The following is a description of a gene set: Genes requiring MLL for H3K4me3 and expression in MEF cells (embryonic fibroblast). from publication Wang P, Lin C, Smith ER, Guo H, Sanderson BW, Wu M, Gogol M, Alexander T, Seidel C, Wiedemann LM, Ge K, Krumlauf R, Shilatifard A (PMID 19703992) species: Mus musculus A common landmark of activated genes is the presence of trimethylation on lysine 4 of histone H3 (H3K4) at promoter regions. Set1/COMPASS was the founding member and is the only H3K4 methylase in Saccharomyces cerevisiae; however, in mammals, at least six H3K4 methylases, Set1A and Set1B and MLL1 to MLL4, are found in COMPASS-like complexes capable of methylating H3K4. To gain further insight into the different roles and functional targets for the H3K4 methylases, we have undertaken a genome-wide analysis of H3K4 methylation patterns in wild-type Mll1(+/+) and Mll1(-)(/)(-) mouse embryonic fibroblasts (MEFs). We found that Mll1 is required for the H3K4 trimethylation of less than 5% of promoters carrying this modification. Many of these genes, which include developmental regulators such as Hox genes, show decreased levels of RNA polymerase II recruitment and expression concomitant with the loss of H3K4 methylation. Although Mll1 is only required for the methylation of a subset of Hox genes, menin, a component of the Mll1 and Mll2 complexes, is required for the overwhelming majority of H3K4 methylation at Hox loci. However, the loss of MLL3/MLL4 and/or the Set1 complexes has little to no effect on the H3K4 methylation of Hox loci or their expression levels in these MEFs. Together these data provide insight into the redundancy and specialization of COMPASS-like complexes in mammals and provide evidence for a possible role for Mll1-mediated H3K4 methylation in the regulation of transcriptional initiation. Human Gene Set: WANG_MLL_TARGETS, and this is the list of marker genes: IGF2BP3, GALNT12, KIF21A, FOXC2, SPRR1A, SOX5, F5, TMEM140, MMP13, FAM20A, HOXB5, IL1RL1, COL14A1, RSRC1, SLIT2, CYP2F1, HOXC6, CYBA, GSTT2, EBF3, HCAR2, CXCL2, PLEK, ATP2B1, VEGFC, TREM2, RABGAP1L, IGFBP6, CISH, SFRP1, DMBX1, PTHLH, KAZALD1, DLL1, CDO1, PDE9A, GAL3ST1, SLC10A6, PTPRM, HOGA1, PPM1L, STAT5A, CD14, AR, PCBD1, C2, TBC1D8, CES2 (carboxylesterase 2), ZIC2, HOXC5, SLC7A2, ETV1, HCCS, COL2A1, B3GALT4, GRB10, PARP14, DGKA, LRIG3, C4BPA, ABCA9 (ATP binding cassette subfamily A member 9), WNK4, RIDA, CLMP, SLIT3, SLC27A3, FABP4 (fatty acid binding protein 4), STXBP6, GATA6, TOX, ANGPT1, PELI2, COL6A1, IL6, FOXS1, RAB3IL1, PKP3, RUBCNL, LDHB, DKK3 (dickkopf WNT signaling pathway inhibitor 3), SERPINB10, MAF, MGP, NT5DC2, NKX6-1, PAX9, EGR3, NAALAD2, CLIP4, MMP2, SHC4, CACNA1A, ADORA2B, CACNA1G, PAX6, ALDH2, CNKSR3, MRC2, IL20RA, ENPEP, SCEL, GDF6, PTGES, NDNF, ARHGEF6, ENPP3, PNMA2, GDA, TMEM119, TMEM35A, CPQ (carboxypeptidase Q), ZNF503, FBXL7, MME, ISLR, MAP3K5, LHFPL1, EMB, CCDC80, THBD, DLX2, KCNJ15, GATA4, PCDHB7, JAM2, TWIST2, HDAC9, CPZ, PLA2R1, SPON2, SLC16A7, GATA3, TGM1, FAM3C (NCBI Gene Id 10447), TGFBR3, ADM, ESR1, UGP2, NFATC4, KRT13, DPEP1, RNF144A, S1PR1, FES, TTC9, APOBEC3B, RSPH9, KCNJ2, ISOC2, EMILIN1 (elastin microfibril interfacer 1), COL6A2, HOXC10, EFHD1, PAX1, ESX1, HLF, EIF4E3, FRMD5, NOTUM, ABHD3, ADAM19, FRZB, VAX2, CYS1 (NCBI Gene Id 192668), ISL2, MAFB, MST1R, HOXC9, BNC1, COL10A1, THBS2, PITX2, DAPP1, ZCWPW1, RENO1, ANO4, MAPK13, MEG3, H6PD, G0S2, SCP2, CHI3L1, HOXC8, CALHM5, SH3RF2, LARP6, PDK4 (pyruvate dehydrogenase kinase 4), NADK2, DHRS3, BAIAP2L1, PLAC8, STEAP4, SH3TC1, S1PR3, PCDHB13, PTGFR, FABP7, GPX7, FOXC1, FGF10, SELENOP, SNED1, RPS6KA6, DAB2, EVA1A, NR4A2, RNF144B, WFDC21P, CNNM2 (NCBI Gene Id 54805), GSTT3P, NAPEPLD (N-acyl phosphatidylethanolamine phospholipase D), FAM13A, FRAT2, HOXC13, CDKN2C, FNDC3A (fibronectin type III domain containing 3A), LGALS3BP (galectin 3 binding protein), ARID5B, DPYD, SMOC2, SFRP2, RASSF9, AGT, ITIH2, SASH1 (NCBI Gene Id 387570), KCNA4, HNF1B, OSR2, TMEM51, STOX2, FUT11, EDA, IL1RN (interleukin 1 receptor antagonist), OMD, NFIA, ASPN, ADH1A (NCBI Gene Id 124), ARHGAP26, HTR2A, AMIGO2, AVPR1A, ALX1, ENPP1, ARHGDIB, MMP14, CCDC68, PLEK2, SMOC1, FOXD1, LPXN, HOXA10, EBF1, GLT8D2, MYLIP, HS6ST2, SVEP1, DUSP2, LAMA1, ASB15, HOXA13, FBN2, TBX15, POSTN, RSPO2, B4GALNT4, HOXB3, SMPDL3B, ARHGAP18 (NCBI Gene Id 93663), SLC8A3, SH3RF3, CYP2S1, GNG8 (NCBI Gene Id 94235), SLCO2A1, SHOX2, HOXB6, CDHR1, EMC2, KCNC2, TGFBI, PTPN22, PAX3, HSD11B1, ABI3BP, GRIP1, RTN4RL1, NEGR1, GPM6B, ASPA, SCARF2, RGS16, DEF6, CABLES1, RNF130, MINAR1